The following is a description of a gene set: from publication Cui A, Huang T, Li S, Ma A, Pérez JL, Sander C, Keskin DB, Wu CJ, Fraenkel E, Hacohen N (PMID 38057668) Mouse Gene Set: CUI_TREG_IL23_RESPONSE_UP species: Mus musculus Cytokines mediate cell-cell communication in the immune system and represent important therapeutic targets. A myriad of studies have highlighted their central role in immune function, yet we lack a global view of the cellular responses of each immune cell type to each cytokine. To address this gap, the authors created the Immune Dictionary, a compendium of single-cell transcriptomic profiles of more than 17 immune cell types in response to each of 86 cytokines (>1,400 cytokine-cell type combinations) in mouse lymph nodes in vivo. A cytokine-centric view of the dictionary revealed that most cytokines induce highly cell-type-specific responses. For example, the inflammatory cytokine interleukin-1β induces distinct gene programmes in almost every cell type. A cell-type-centric view of the dictionary identified more than 66 cytokine-driven cellular polarization states across immune cell types, including previously uncharacterized states such as an interleukin-18-induced polyfunctional natural killer cell state. Genes positively differentially expressed in cell type: Treg upon treatment with cytokine: IL-23 in mouse lymph nodes in vivo., and this is the list of marker genes: H2-D1, Rnaset2b, Sh3glb2, H2-Q4, Tmsb10, Arpc4